The following is a description of a gene set: Mouse Gene Set: chr10D1 studied in species Mus musculus, and this is the list of marker genes: Gad1-ps, Gm22236, Zdhhc17, Osbpl8, Alyreffm9, Alyreffm10, Nap1l1, Mettl25, Gm35533, Gm35206, Gm19181, Ptprq, Alyreffm11, Pawr (NCBI Gene Id 76427), Dusp6, 4930532I03Rik, Gm25143, Acss3, Gm19007, Alyreffm15, Gm9476 (NCBI Gene Id 670007), Gm17849, Gm16239, 1700017N19Rik, Gm18040, Gm8701, Csl, Gm35035, Gm8723, Gm4310 (predicted gene 4310), Alx1, Alyreffm8, Cep290, Gm23041, Alyreffm7, Otogl, Mir3059, Gm26923, Gm48089, Gm22339, Gm26278, Gm4781, Gm8711, Slc6a15, Gm34921, Alyreffm5, Or8o1-ps1, Syt1, Kitl, Gm29674, Gm24745, Gm25587, Gm15663 (NCBI Gene Id 327812), Ppp1r12a, Alyreffm16, Lrriq1, Ccdc59, Rlig1, 3110043J17Rik, Gm5176, Nav3, Gm30624, Gm25522, Alyreffm4, Bbs10, Gm25342 (predicted gene, 25342), Alyreffm17, 4933440J02Rik (NCBI Gene Id 71321), Gm35722, Mgat4c, 9230102K24Rik, Gm8873, Rpl6l, Gm34983, 1700020G17Rik, Phlda1, Gm19005, Rassf9, Myf5, Tmtc2, Gm19233, Alyreffm6, Gm8796 (NCBI Gene Id 667758), Gm22945, Alyreffm12, Lin7a, Myf6, Gm29685, Gm20758, Gm8689, E2f7, Gm47340, Gm25422, Alyreffm13, Gm30262, Gm25376, Csrp2, Gm35101, Rps15a-ps1, Brcc3dc, Gm15666, Gm18409, B530045E10Rik, Gm46193, Gm23698, Gm36283, Gm22186, Gm5175, Alyreffm14, Gm26988 (NCBI Gene Id 676776), Mir6411, Gm34574, Nts, Gm23105, Gm17870, Gm34777, Ppfia2, Gm25117, Gm8768, Tmtc3, Gm4898, Gm40761